The following is a description of a gene set: Human Gene Set: HP_RED_HAIR Red hair studied in species Homo sapiens, and this is the list of marker genes: MC1R, ZNF469, PCSK1, POMC, TYRP1, PDE4D, PRKAR1A (protein kinase cAMP-dependent type I regulatory subunit alpha), OCA2